Given this list of marker genes NEDD4, COMMD1 (copper metabolism domain containing 1), RSC1A1, CAMK2D, SCN1B, SCN3B, PCSK9, NEDD4L, here is a description of the gene set: Human Gene Set: GOMF_SODIUM_CHANNEL_INHIBITOR_ACTIVITY Binds to and stops, prevents, or reduces the activity of a sodium channel. species: Homo sapiens